Given this list of marker genes Ctnnb1, Fam124b, Chd8, here is a description of the gene set: Reactome Pathway: CHD6, CHD7, CHD8, CHD9 subfamily part of: CHD chromatin remodelers studied in species Mus musculus electronically inferred by orthology from the curated human pathway This event has been computationally inferred from an event that has been demonstrated in another species.<p>The inference is based on the homology mapping from PANTHER. Briefly, reactions for which all involved PhysicalEntities (in input, output and catalyst) have a mapped orthologue/paralogue (for complexes at least 75% of components must have a mapping) are inferred to the other species.